The following is a description of a gene set: species: Mus musculus Mouse Gene Set: GOBP_CELLULAR_RESPONSE_TO_LEPTIN_STIMULUS Any process that results in a change in state or activity of a cell (in terms of movement, secretion, enzyme production, gene expression, etc.) as a result of a leptin stimulus. Leptin is a hormone manufactured primarily in the adipocytes of white adipose tissue, and the level of circulating leptin is directly proportional to the total amount of fat in the body. It plays a key role in regulating energy intake and energy expenditure, including appetite and metabolism., and this is the list of marker genes: Sirt1 (NCBI Gene Id 93759), Mkks, Inhbb, Nr4a3, Prmt2, Lepr, Bbs4, Mt3, Ccna2, Pten, Lep (NCBI Gene Id 16846), Adipor1, Fgb, Pid1, Gck, Fgf23, Ugcg, Bbs2, Acbd7, Stat3